The following is a description of a gene set: species: Homo sapiens Human Gene Set: GOMF_LIGASE_ACTIVITY_FORMING_CARBON_OXYGEN_BONDS Catalysis of the joining of two molecules via a carbon-oxygen bond, with the concomitant hydrolysis of the diphosphate bond in ATP or a similar triphosphate., and this is the list of marker genes: YARS1, CARS2, TARS1, TARS2, LARS2, GARS1, EPRS1, FARS2, IARS1, DARS1, KARS1, VARS1, AARS2, AARS1, MARS1, QARS1, RARS1, EARS2, HARS2, CARS1, DARS2 (NCBI Gene Id 55157), DALRD3, NARS1 (asparaginyl-tRNA synthetase 1), AARSD1, LARS1, TARS3, HARS1 (histidyl-tRNA synthetase 1), RARS2, NARS2, WARS2, IARS2, LRRC47, WARS1, FARSB, PARS2, SARS2, SARS1, FARSA, VARS2, MARS2, YARS2